Given this list of marker genes OXSM, ACACA, HTD2, HSD17B12, MCAT, MECR, here is a description of the gene set: Mitochondrial fatty acid synthesis pathway species: Homo sapiens Human Gene Set: WP_MITOCHONDRIAL_FATTY_ACID_SYNTHESIS_PATHWAY